The following is a description of a gene set: species: Homo sapiens Anomalous structure of a blood vessel in the kidney. Human Gene Set: HP_ABNORMAL_RENAL_VASCULAR_MORPHOLOGY Abnormal renal vascular morphology, and this is the list of marker genes: IL12B, GEMIN4, TMEM127, MLXIPL, VAC14, ABCG8, POU3F4, HLA-B, LDLR, APOB, MLX, ABCG5, PCSK9, FIG4, WDR19, RET (NCBI Gene Id 5979), JAG1, NF1, PNPLA2, ENPP1, ELN, STAT1, LDLRAP1, YY1AP1, ALG9, VHL, MAX, ADA2